Given this list of marker genes LPL, CETP, APOA1 (NCBI Gene Id 335), LIPC, PLTP, APOA5, LCAT, ANGPTL3, GPIHBP1, LRP1 (NCBI Gene Id 4035), APOC2, ANGPTL4, SEL1L, LDLR, APOA4, ANGPTL8, APOA2, LMF1, here is a description of the gene set: Familial hyperlipidemia type 1 studied in species Homo sapiens Human Gene Set: WP_FAMILIAL_HYPERLIPIDEMIA_TYPE_1